Given this list of marker genes SEC61A2 (NCBI Gene Id 88207), ARL6IP1, SEC61A1, SEC61B, SSR4, SEC61G, here is a description of the gene set: Human Gene Set: GOCC_TRANSLOCON_COMPLEX A protein complex that constitutes a specific site of protein translocation across the endoplasmic reticulum, which involves the signal recognition particle receptor. The complex contains a core heterotrimer of alpha, beta and gamma subunits, and may contain additional proteins. species: Homo sapiens